The following is a description of a gene set: from publication McBryan J, Howlin J, Kenny PA, Shioda T, Martin F (PMID 17486082) Expression microarray analysis identified over genes regulated during puberty in the mouse mammary gland. Most prominent were genes whose expression increased in parallel with pubertal development and remained high thereafter. Members of the Wnt, transforming growth factor-beta and oestrogen-signalling pathways were significantly overrepresented. Comparison to expression data from CITED1 knockout mice identified a subset of oestrogen-responsive genes displaying altered expression in the absence of CITED1. Included in this subset are stanniocalcin2 (Stc2) and amphiregulin (Areg). Chromatin immunoprecipitation revealed that ERalpha binds to oestrogen response elements in both the Stc2 and Areg genes in the mammary gland during puberty. Additionally, CITED1 and ERalpha localize to the same epithelial cells of the pubertal mammary gland, supporting a role for interaction of these two proteins during normal development. In a human breast cancer data set, expression of Stc2, Areg and CITED1 parallel that of ERalpha. Similar to ERalpha, CITED1 expression correlates with good outcome in breast cancer, implying that potential maintenance of the ERalpha-CITED1 co-regulated signalling pathway in breast tumours can indicate good prognosis. Mouse Gene Set: MCBRYAN_PUBERTAL_BREAST_5_6WK_DN Genes down-regulated during pubertal mammary gland development between week 5 and 6. species: Mus musculus, and this is the list of marker genes: Vapb, Iigp1, Keap1, Ppp2r5b, Ykt6, Cnot3, Nfic, Lasp1, Gpd1, Sox9, Adissp, Acaca, Prrx1, Atp8a1, Malat1, Fscn1, Egln1, Cald1, Akt2, Srek1, Tmem79, Pten, Ywhag, Airn, Zfhx3, Gys2, Map4k2, Cygb, Fzd4, Csnk2a1, Norad (non-coding RNA activated by DNA damage), Smc6, Zbtb20, Eif4ebp2, Nfib, Ip6k1, D17H6S56E-5, Tpr, Tns1 (tensin 1), Secisbp2l, Hemk1, Slc2a4 (solute carrier family 2 (facilitated glucose transporter), member 4), Arhgef2, Akap9 (A kinase anchor protein 9), Thrap3, Wnk1, Pank3, Atp1a3, Dnmt3a, Smarca4, Kcnb1, Sec61a1, Sppl2a, Cspg4, Fign, Ccnd2, Rad23a, Srpk2, Dapk1, Ogt, Ubd, Ehd2, Cyth1, Dhx36, Rpl37a, Kdm5a, Mapk14, Itsn2 (NCBI Gene Id 20403), Wasl, Sdc4, Nrip1, Fto, Zeb2, Xist, Lalba, Dbp, Chd4, Hsd17b11, Mapk8, Slc25a10, Dpysl3, Qpctl, Hdlbp, Acly, Rgs5, Il6ra, Nfatc3, Ddx6, Pank1, Fubp1, Rbm5 (RNA binding motif protein 5), Nfix, Eif4g1, Ebf3, Cpd, Atxn7l3b, Ogfr, Fus, Brd4, Mbtps1, Stat5b, Qki, Pdap1, Slc38a10, Rab5c, Fgg, Sfpq, Ppp6r3, Neat1, Runx1, Rbbp4, Il6st, Tbl1x, Eif3c, Slc2a5, Cox8b, Resf1, Lpgat1 (NCBI Gene Id 98667), Sirpa, Mef2c, Prpf19, Purb, Clec3b, Gbp7, Cux1, Zbtb7b, Sntb2, Bltp2, Taok1, Ndst1, Crim1, Cavin1, Pcyt1a, Tyr